Given this list of marker genes Aph1c, Pgm1, Vash1, Haus2, Camk2d, Gm5878, Psg16, Vkorc1l1 (vitamin K epoxide reductase complex, subunit 1-like 1), Fzd7, Rab30, Bard1, Zc3h8, Gtf2h1, Gpr19, Atf2, Psg25, Tsc22d2, Cdk17, Tlcd4, Rhov, Lin28b, Tsen2, Gtf3c1, Mllt1, Dmac2l, F5, Slc20a2, Lrrc8a, Lsamp, Wdr33, Nucb2, 5730507C01Rik, Ccnd2, Nr3c1, Retreg3, Dlc1, Aebp2, Chl1, Gxylt1, Amotl1, Prickle2, Ankrd44, Grk6, Nr3c2, Smarcal1, Zfp106, Bmp3, Pcdh9, Palld, P2ry12, Wipf3, Spdye4b, here is a description of the gene set: from publication Chen Y, Wang X (PMID 31504780) Mouse Gene Set: MIR_6939_3P species: Mus musculus Genes predicted to be targets of miRBase v22 microRNA mmu_miR_6939_3p in miRDB v6.0 with MirTarget v4 prediction scores > 80 (high confidence targets).